The following is a description of a gene set: species: Homo sapiens Human Gene Set: HP_ABNORMAL_SIZE_OF_THE_DENTAL_ROOT Abnormal size of the dental root, and this is the list of marker genes: WNT10B, EDA, IRF6, SMOC2, MSX1, WNT10A, TGFA, FGFR1, SUMO1, TONSL, EDARADD, IFIH1, BCOR, PAX9 (paired box 9), LRP6, AXIN2